Given this list of marker genes Phf20, Plekha6, Tifab, Hic2, Kcnip1, Tmem121, Rundc3a, Dtna, Spred1, Phyhipl, Fzd7, Syt5, Dab2ip, Gpx3, Kbtbd7, Arid3b, Gnb1, Cacna2d2, Ptdss2, Unc5b, Brd2, Rusc2, Srf, Hap1, Dennd6a, Nhlrc3, Ctif, Smim13, Ccdc177, Ephb3, Pdpk1, Pef1, Cpsf7, Pianp, Gm3604, Cd82, here is a description of the gene set: species: Mus musculus Mouse Gene Set: MIR_874_5P from publication Chen Y, Wang X (PMID 31504780) Genes predicted to be targets of miRBase v22 microRNA mmu_miR_874_5p in miRDB v6.0 with MirTarget v4 prediction scores > 80 (high confidence targets).